The following is a description of a gene set: Mouse Gene Set: GOCC_POSTSYNAPTIC_EARLY_ENDOSOME An early endosome of the postsynapse. It acts as the major sorting station on the endocytic pathway, targeting neurotransmitter receptors for degregation or recycling. studied in species Mus musculus, and this is the list of marker genes: Snx6, Gripap1, Rab5a, Pick1, Eea1, Snx27, Vps26b